The following is a description of a gene set: species: Mus musculus Genes predicted to be targets of miRBase v22 microRNA mmu_miR_504_3p in miRDB v6.0 with MirTarget v4 prediction scores > 80 (high confidence targets). from publication Chen Y, Wang X (PMID 31504780) Mouse Gene Set: MIR_504_3P, and this is the list of marker genes: Vti1a, Mycl, Nhlh1, Pcdha12, Shisa6, Sp1, Enam, Psg19, Psg26, Rapgefl1, Prox1, Slc16a10, Prkcg, Heyl, Gne, Gng7, Cep135, Slc4a10, Otof, Pcdhac2, Kdm2a, Pcdhac1, Tpbgl, Coro7, Adcyap1r1, Hrh3, Mpp2, Setbp1, Pcdha5, Hnf1b, Trp53inp2, Ppp1r9b, Ndst1, Rasl11b, Apba1, Cdc14b, Synj2bp, Cyyr1, Arl8a, Bak1, Hmgn2, Sting1, Arhgef40, Nfat5, Tmem176b, Atg4b, Psg25, Zfp282, Bptf, Prdm2, Etv3, Pmm2, Tom1l2, Sgo2a, Slc20a1, Aoc3, Kcnj15, Mlst8, Nipsnap1 (NCBI Gene Id 216519), Tmem229b, Tac4, Strip2, Tceanc2, Trpm2, Foxk1, Uqcc4, Dusp22, Cops7b, Zfp703, Cyp2j13, Tnik, Rab8a, Map3k3, Plpp6, Tnfaip8l2, Frem2, Wars1, Hipk1, Gsk3b, Focad, Pcdha11, Rbm20, Gigyf1, Arhgef9, Igsf9b, Bbln, Six2, Ubqln4, Bcl11b, Noto, Fkbp15, Slc25a42, Pcdha3, Pianp, Ucn3, Asic1, Psg17, Tmx4, Lpcat3, Ap3s2, Adissp, Rbm11, Pcdha1, Jak1, Myo18a, Astn2, Nbl1, Trim58, Dhx40, Chek1, Mtcl2, Pnpla3, Ccdc102a, Pcdha2, Hmg20a, Chd3, Clec16a, Atp1a3, Pcdha4, Tpbpa, Tnfrsf22, Eya3, Fst, Zfp26, Smg7, Zfp395, Cd79b, Zfp53, Frmpd3, Akr1e1 (NCBI Gene Id 67508), Gpatch2, Brpf3, Spats2, Vip, Pik3r5, Tmem51, Pbx1, Spag17, Flot2, Pcdha6, Eif4e1b, Plxna4, Git1, Pax2, Gpr25, Emilin3, Hmgcll1, Eif1a, Mul1, Slc24a3, Notum, Sesn2, Pcdha8, Prrg3, Zfp608, Me3, Chst1, Arhgap45, Prdm14 (PR domain containing 14), Dlx3, Wnt1, Sumf2, Pcdha9, Exd2, Kcnip2 (Kv channel-interacting protein 2), Odad1, Pcyt1b, Ptprn2 (NCBI Gene Id 73860), Cercam, Arl14epl, Slc9a1, Rgs20, Aqp6, Nampt, Pcdha7, Taok3, Hba-a2, S1pr2, Carmil3, Aqp4, Fam53b (family with sequence similarity 53, member B), Dynll2, Fmn1, Srebf2, Polr3f, Lynx1, Gatad2a, Atxn7l3, Fbxl19, Syp, Csmd2, Mkks, Gfap, Shank1, Gon4l, Tmem63b, Samhd1, Mmrn2, Zfp362, Nhlrc1, Psg27, Sdhaf2, Nfatc4, Rab37, Fzd6, Abcg4, Cux2, Magi3, Zbtb34, Pcdha10, Fank1, Dagla